The following is a description of a gene set: studied in species Homo sapiens Endoderm differentiation Human Gene Set: WP_ENDODERM_DIFFERENTIATION, and this is the list of marker genes: BPTF, CTR9, TET1, LHX1, APC, POU5F1, SP4 (Sp4 transcription factor), TOX3, PRDM14, EPB41L5, MBTD1 (mbt domain containing 1), WDHD1, BTAF1, ELP4, HHEX, ELAVL1, CEBPZ, RARG, KDM4A, WNT3, SMAD2, GRHL2, DAB2, LAMC1, DKK1, GDF3, NLK, PAX3, MIR141, PTHLH, C1QBP, NODAL, OTX2, BCORL1, GATA6, NOTCH1, ZBTB17, ATP8B2, NOG, PBX1, LEO1, WWC1, PLCH1, MAP2K3, EXT1, RFX7, RGS10, PBX3, FOXO1, WNT8A, NKX2-1, DNMT3B, SLC2A12, TCEAL2, ZIC3, TCF4, TNRC6C, DUSP4 (NCBI Gene Id 1846), ZFHX4, MIXL1, APP, CER1, HNF1B, EZH2, SMAD4, PABPC1 (NCBI Gene Id 26986), LEF1, FOXH1, DUSP5, AEBP2, TRERF1, PAF1, HPRT1, CEP250, TAF5, MTF2, CDC73, JARID2, NCAPG2, ELK4, RAB38, CTBP2, FOXA1, CDYL, CRTC1, BMPR1A, NAA15, SFMBT1, CUL4B, FOXA2, EMSY, NANOG, SFRP1, DIP2A, TRIM71, ACACA, SOX17 (SRY-box transcription factor 17), DUSP2, WDFY2, FOXN3, EOMES, TGFB1, TOX, PIAS1, MIR375, BMP7, HOXA1 (homeobox A1), NME1, LRPPRC, ZNF281, SIAH2, ASCC3, GLI2, CAND1, SESN1, PARP8, CTNNB1, ZNF462, STAT1, SMAD3, NR3C1 (nuclear receptor subfamily 3 group C member 1), NABP2, PHF6, PAX9, MIR373, GATA4, ZIC5, MAD2L2, ONECUT1, SOX21, VAV3, TAF4B, SOX7, DDAH1 (dimethylarginine dimethylaminohydrolase 1), AHDC1, RTF1, TRIM5, UBR5, HOXC11, TCF7L1, TCF7, SOX2, TBX21